Given this list of marker genes CFTR, SCNN1B, SELENBP1, SCNN1A, MAT1A, SCNN1G, here is a description of the gene set: species: Homo sapiens Noticeably unpleasant odors exhaled in breathing. Halitosis Human Gene Set: HP_HALITOSIS